Given this list of marker genes Asns, Cxcl1, Nat8, Fst, Bcl6, Eif2s3y, here is a description of the gene set: Genes down-regulated in tumorous liver tissues from PARK2 knockout mice compared to the normal, non-tumorous tissue from wild type mice. species: Mus musculus The parkin was first identified as a gene implicated in autosomal recessive juvenile Parkinsonism. Deregulation of the parkin gene, however, has been observed in various human cancers, suggesting that the parkin gene may be important in tumorigenesis. To gain insight into the physiologic role of parkin, we generated parkin-/- mice lacking exon 3 of the parkin gene. We demonstrated here that parkin-/- mice had enhanced hepatocyte proliferation and developed macroscopic hepatic tumors with the characteristics of hepatocellular carcinoma. Microarray analyses revealed that parkin deficiency caused the alteration of gene expression profiles in the liver. Among them, endogenous follistatin is commonly upregulated in both nontumorous and tumorous liver tissues of parkin-deficient mice. Parkin deficiency resulted in suppression of caspase activation and rendered hepatocytes resistant to apoptosis in a follistatin-dependent manner. These results suggested that parkin deficiency caused enhanced hepatocyte proliferation and resistance to apoptosis, resulting in hepatic tumor development, partially through the upregulation of endogenous follistatin. The finding that parkin-deficient mice are susceptible to hepatocarcinogenesis provided the first evidence showing that parkin is indeed a tumor suppressor gene. Mouse Gene Set: FUJIWARA_PARK2_IN_LIVER_CANCER_DN from publication Fujiwara M, Marusawa H, Wang HQ, Iwai A, Ikeuchi K, Imai Y, Kataoka A, Nukina N, Takahashi R, Chiba T (PMID 18574468)